The following is a description of a gene set: Broad first metatarsal studied in species Homo sapiens Human Gene Set: HP_BROAD_FIRST_METATARSAL Increased side-to-side width of the first metatarsal bone., and this is the list of marker genes: ABCC9, FGFR2, CANT1, FGFR1, NEK1, IFT56